Given this list of marker genes SRRM2, PGAP1, RUSC2, SPG11, HUWE1, HIVEP2, TRPM3, MYT1L, SHOC2, ITPR1, PIGO, UBE3A, CTNNB1, WDR81, TRIM8, PHEX, SDHB, KDM1A, TMEM163, MID1, FBXO11, FLVCR1, SLC37A4, ATP6V1A, MPZ, GPRC5B, TAF4, SELENON, VPS13B, RYR1, RAB3GAP2, WDR26, SLC25A12, HK1, CNOT3, ARID1B (AT-rich interaction domain 1B), MARS1, TANGO2, CRBN, XYLT1, MACF1, GRIA4, KAT6A, SOX4, SON, EIF2B4, ATP6V0A1, AHI1, TIMM50, CUBN, NCAPG2, CCDC134, NFU1, POLR2A, DYNC1H1, SLC16A2, ZFX, SMARCD1, ADCY5, TRMT1, RTN2, CHAMP1, LMNA, ASCC3, AP4S1, TNPO3, GNPTAB, NDUFA1, PIGC, CLCNKB, DOLK, COPB1, STAG2 (NCBI Gene Id 10735), SPOP (NCBI Gene Id 8405), CASK, LRRC32, AHDC1, PGM2L1, KPNA3, FOXG1, POLR3B, SEMA6B, ALS2, AP3B2, ZNF148, PIEZO2, MSL3, SYNE1, AP1S2, SLC25A1, EIF2AK1, DOCK3, WASHC4, COASY, LARGE1, BRAT1, SIGMAR1, ZC4H2, PACS2, HNRNPC, DCPS (decapping enzyme, scavenger), TRAPPC9, KARS1 (NCBI Gene Id 3735), ERLIN2, SNAP25, ZNF407, PPP2CA, HERC2, CHD3, WDR4, KDM5B, BRPF1, KMT2E, FOXP1, COL3A1, GRIN1, ATP10A, RAI1, DPF2, TMEM106B, FAR1, CLCN3, MBOAT7, FRMPD4, FBLN1, FTH1, CPLX1, COL12A1, HYCC1, SLC12A2, COL6A2, SLC9A1, NMNAT1, AP4E1 (adaptor related protein complex 4 subunit epsilon 1), PUM1, NFASC, MCM3AP, CNKSR2, PLP1, SCAF4, SET, FBXL3, SNRPN, MAGEL2, YY1, NCDN, HECW2, SPTSSA, BSND, TMEM147, WDR45, LAMA2, CDK10, COL6A3, PAK3, ASXL3, BCL11B, PLOD1, SMC1A, NBEA, ARL13B, HS6ST2, SATB1, MRPS14, SETD5, TCF20, PIGG, CLCNKA, RUBCN, GRIK2, DDOST, DHX30, FASTKD2, ROGDI, SLC5A7, TMEM222, ALMS1, RYR3, RALA, CUL3, GALNS, DLAT, ADGRL1, ZBTB11, SRCAP, MKS1, TRRAP, ZEB2, TRAPPC10 (trafficking protein particle complex subunit 10), ABCA2, SLC9A7, TMEM94, NEUROD2, SYT1 (synaptotagmin 1), PRMT7, EBF3, RPL10, LBR, INPP5E, CDK13, CREBBP, RORA, SMARCA2, WASF1 (WASP family member 1), NDUFA12, CLDN11, TTI1, GET4 (guided entry of tail-anchored proteins factor 4), EXOC6B, RETREG1, ATG5, P4HTM, TTI2, LMNB2, TFG, MEF2C, HDAC4, CADM3, DPM3, EIF3F, CYP3A4, ABCB7, FITM2, CTCF, ATG7, TRIO, ODC1, TBR1 (T-box brain transcription factor 1), IQSEC1, COG1, RAD51 (RAD51 recombinase), TMTC3, DPYSL5, CSNK2A1, FKBP14, PMPCA, CSNK2B, FUS, POMT1, RNU12, CELF2, AGO1, PUS7, GALNT2, MEGF8, TRIT1, KPTN, CFL2 (cofilin 2), PNPLA2, HMBS, KLHL15, MAPK8IP3, BCL11A, LMNB1, RAB11B, VLDLR, NARS1, DHPS, CAMK2A, RNU4-2, AP4B1, POLR1A, AMN, NONO, SLC25A42, MYO9A, MTPAP, RAB3GAP1, ACBD6, OPHN1, CHMP1A, ZSWIM6, PAK1, ACTN2, ADARB1, CHRNB1, NUDT2, PPP2R5D, TRIM2, EP300, MRPS25, OTUD7A, POMK, MECP2, IFT27, RBL2, JAG1, HNRNPK, CWC27, SPTLC1, SCN8A, KDM3B, CCDC22, CYP2U1, LSS, GNAI1, PCYT2, NFIX, TPM2, MRAS, DYNC1I2, GARS1, DAG1, POLR1C, AMPD2, H3-3A, TMEM63A, CNTNAP2, SHMT2 (NCBI Gene Id 6472), SLC18A2, here is a description of the gene set: Human Gene Set: HP_DELAYED_ABILITY_TO_WALK studied in species Homo sapiens Delayed ability to walk A failure to achieve the ability to walk at an appropriate developmental stage. Most children learn to walk in a series of stages, and learn to walk short distances independently between 12 and 15 months.